The following is a description of a gene set: species: Homo sapiens Genes up-regulated in H1975 cells (non-small cell lung cancer, NSCLC) resistant to gefitinib after treatment with EGFR inhibitor CL-387785 for 24h. Human Gene Set: KOBAYASHI_EGFR_SIGNALING_24HR_UP from publication Kobayashi S, Shimamura T, Monti S, Steidl U, Hetherington CJ, Lowell AM, Golub T, Meyerson M, Tenen DG, Shapiro GI, Halmos B (PMID 17145885) Activating mutations in the epidermal growth factor receptor (EGFR) tyrosine kinase domain determine responsiveness to EGFR tyrosine kinase inhibitors in patients with advanced non-small cell lung cancer (NSCLC). The modulation of transcriptional pathways by mutant EGFR signaling is not fully understood. Previously, we and others identified a single base pair change leading to a threonine to methionine (T790M) amino acid alteration in the ATP-binding pocket of the EGFR as a common mechanism of acquired resistance. The gefitinib-resistant, T790M-mutant H1975 NSCLC cell line undergoes prominent growth arrest and apoptosis when treated with the irreversible EGFR inhibitor, CL-387,785. We did a transcriptional profiling study of mutant EGFR target genes that are differentially expressed in the resistant gefitinib-treated and the sensitive CL387,785-treated H1975 cells to identify the pivotal transcriptional changes in NSCLC with EGFR-activating mutations. We identified a small subset of early gene changes, including significant reduction of cyclin D1 as a result of EGFR inhibition by CL-387,785 but not by gefitinib. The reduction in cyclin D1 transcription was associated with subsequent suppression of E2F-responsive genes, consistent with proliferation arrest. Furthermore, cyclin D1 expression was higher in EGFR-mutant lung cancer cells compared with cells with wild-type EGFR. EGFR-mutant cells were routinely sensitive to the cyclin-dependent kinase inhibitor flavopiridol, confirming the functional relevance of the cyclin D axis. These studies suggest that cyclin D1 may contribute to the emergence of EGFR-driven tumorigenesis and can be an alternative target of therapy., and this is the list of marker genes: GPNMB, H2BC21, EPB41L1, H2BC5, HMOX1, CTSH, VAV3, PSG1, GRN, FTH1, AQP3, CPE, HCFC1R1, KLHL24, AOPEP, AKR1B10, EPHX1, WDR45, CD74, MXI1, PPL, PSG7, TBC1D9, ALDH6A1, FZD5, NEBL, TRIM2, CYP1B1, S100P, TJP3, TSC22D3, FXYD3, IRF7, ANXA8, SYNE2, CPD, ACSL1, BDH2, HLA-DMA, LIMCH1, PBXIP1, H2BC12L, H2BC12, NIBAN1, TMT1A, SOX4, ID2, TP53TG1, HEG1, YPEL5, EDIL3, ZSCAN31, PROS1, BCAM, SCNN1A, SELENBP1, TPP1, CCN5, GLUL, CLDN3, PIK3R3, BCL6, H3C10, DPYD, LXN, ST6GALNAC2, DEPTOR, DRAM1, CALCOCO1, MAN1A1, ADCY9, H2AC6, PSMB10, PIK3IP1, ASS1, CEP68, PELI1, CCNG2, CBLB, ZNF117, ABHD4, NUPR1, PSG6, VPS13C, CEBPD, MAOA, GPX3, CDK19, ACP5, H1-2, PSG4, GSN, PDCD4, H2AC18, H2BC7, PSG3, AHNAK2, RAB15, PSG9, PBX1, MUC1, ID3, ANXA4 (annexin A4)